The following is a description of a gene set: Genes positively differentially expressed in cell type: cDC1 (conventional dendritic cell type 1) upon treatment with cytokine: IFN-γ in mouse lymph nodes in vivo. from publication Cui A, Huang T, Li S, Ma A, Pérez JL, Sander C, Keskin DB, Wu CJ, Fraenkel E, Hacohen N (PMID 38057668) species: Mus musculus Mouse Gene Set: CUI_CDC1_IFNG_RESPONSE_UP Cytokines mediate cell-cell communication in the immune system and represent important therapeutic targets. A myriad of studies have highlighted their central role in immune function, yet we lack a global view of the cellular responses of each immune cell type to each cytokine. To address this gap, the authors created the Immune Dictionary, a compendium of single-cell transcriptomic profiles of more than 17 immune cell types in response to each of 86 cytokines (>1,400 cytokine-cell type combinations) in mouse lymph nodes in vivo. A cytokine-centric view of the dictionary revealed that most cytokines induce highly cell-type-specific responses. For example, the inflammatory cytokine interleukin-1β induces distinct gene programmes in almost every cell type. A cell-type-centric view of the dictionary identified more than 66 cytokine-driven cellular polarization states across immune cell types, including previously uncharacterized states such as an interleukin-18-induced polyfunctional natural killer cell state., and this is the list of marker genes: Hk3, Hsdl2, Gbp8, Slfn2, Denr, Tcf7l2, Dnase1l3, Ifi47, Arf4, Zyx, Fuca1, Bst1, Gnb1, Hsd17b11, Isg15, Apobec3, Spint1, Pdk3, Tspo, Hhex, Slc33a1, Smagp, Tbcb, Trafd1, Mapk13, Stoml1, Elmo2, Acadl, Tapbpl, Eif2ak2, Sumo2, Cxcl10, Psma7, Serpina3g, Gbp9, Ube2l6, Cst3, Pkib, Icam1, Irgm2, Gbp2, Dtx3l, Ndrg1, Akr1a1, Cttnbp2nl, Ly6a, Vdac2, Arf6, Fgl2, Gatm, Serpinb9, Selenow, Clic4, Uba7, Lap3, Arrdc4, Procr, Vim, Fam174a, Gnb4, Cyba, Prdx1, Rab7, Marchf5, Sfr1, Cpne3, Ece1, Tap2, Nrros (NCBI Gene Id 224109), Slc4a8, Pmepa1, Casp4, Parp9, Iigp1, Aida, Stxbp3, Gpr33, Slfn5, Rngtt, Etv6, Plaat3, Klrk1, H2-T23, Il4ra, Gbp5, Apol7c, Parp11, Psma3, Stat3 (signal transducer and activator of transcription 3), Csrp1, Bst2, Ptms, Nampt, Psme1, Calhm6, Nmi, Il15, Tmbim6 (NCBI Gene Id 68309), Tmem106a, Coro1b, Pdia3, Vwf, Ifi204, Stat2, Cyrib, Serpina3f, Ppa1, Sp110, Rer1, Tgtp1, Rnf213, Cd40, Mthfd2, Pgap2, Ube2n, Slc8b1, H2-D1, Pnp, Wfdc17, Pml, Gbp4, Tap1, Psmb10, Lamp2, Txndc17, Cd24a, Tnf (tumor necrosis factor), Pim1, Ly6e, Chuk, Parp14, Myd88, Ifi205, Tapbp, Herc6, Irgm1, Max, Lrrc8c, Ccnd2, Psme2 (NCBI Gene Id 19188), Tle3, Itga4, Hnrnph2, Hif1a, Irf7, Zmiz2, Gpd2, Creb3, Samhd1, Xaf1, Ogfr (opioid growth factor receptor), Ifitm3, Snap23, Anxa4, Wars1 (NCBI Gene Id 640248), Lgals9, Psma2, Cmpk1, Il18bp, Apol10b, Psma4, Pfkp, Fcgr4, Zbp1, Parp12, Arhgap15, Pcmtd1, Spop, Socs1, Ifi211, H2-K1, B2m, Nlrc5, Polr2i, Cd86, Lgals3bp, Pfn1, Psmb9, Stat1, Serpinb6b, Cxcl9, Il10ra, Igtp, Flot2, Zup1, Basp1, Scpep1, Slamf8, Lpp, Hprt1, Lgals3, Isg20, Mbd2, Gbp3, Bbx, Snx6, Fbxw17, Xcr1, Clec2d, Litaf, Irf8 (NCBI Gene Id 15900), Irf1, Txn1